The following is a description of a gene set: Calcium-dependent catalysis of the reactions: ATP + a protein serine = ADP + protein serine phosphate; and ATP + a protein threonine = ADP + protein threonine phosphate. studied in species Mus musculus Mouse Gene Set: GOMF_CALCIUM_DEPENDENT_PROTEIN_SERINE_THREONINE_KINASE_ACTIVITY, and this is the list of marker genes: Camk2n2, Mapkapk5, Camk4, Mapkapk3, Camk2b, Prkcd, Prkd2, Prkd1, Prkca, Hmgb1, Mapkapk2, Prkci, Prkcq, Prkcb, Mknk1 (NCBI Gene Id 80631), Prkch, Prkce, Prkcz, Camk2n1, Prkd3, Pkn2, Prkcg, Mknk2, Cib1, Pkn1, Pkn3